Given this list of marker genes ETV6, TDRD7, TDRD1, TDRD6, TFCP2L1, SOS1, NAGLU, CAPZA3, RRN3, PADI6, TDRD5, KIF5B, FOSL1, PLD6, ZMIZ1, TDRKH, here is a description of the gene set: Human Gene Set: GOBP_CYTOPLASM_ORGANIZATION studied in species Homo sapiens A process that is carried out at the cellular level which results in the assembly, arrangement of constituent parts, or disassembly of the cytoplasm. The cytoplasm is all of the contents of a cell excluding the plasma membrane and nucleus, but including other subcellular structures.